Given this list of marker genes Ctsz, Plat, Cpb2, Thbs1, Serpinf2, Serpine1, Plau, Serpine2, here is a description of the gene set: studied in species Mus musculus Mouse Gene Set: GOBP_NEGATIVE_REGULATION_OF_PLASMINOGEN_ACTIVATION Any process that decreases the rate, frequency or extent of plasminogen activation. Plasminogen activation is the process in which plasminogen is processed to plasmin.